Given this list of marker genes LANCL2, GGT2P, GGT1, GGT3P, PAM, PGLYRP2, LANCL1 (LanC like glutathione S-transferase 1), LANCL3, here is a description of the gene set: The covalent alteration of one or more amino acid residues within a peptide, resulting in a change in the properties of that peptide. Human Gene Set: GOBP_PEPTIDE_MODIFICATION studied in species Homo sapiens